Given this list of marker genes TERF2, PFDN5, KLHL6, UVSSA, ABRAXAS2, TLR6, IRS2, IRF2, HIVEP3, SPPL3, PGGT1B, EIF3H (eukaryotic translation initiation factor 3 subunit H), AKNA, LGALS1, MAP3K10, CCPG1, EIF3K, LIMK2, STK24, TMEM9B, KIAA0040, INPP5K, SHISA5, CLK3, C19orf12, ZSCAN25, VAMP8, ERP29, BRD4, MXD1 (NCBI Gene Id 4084), SSBP2, MAP1LC3B, STAT4, IFI27L2, VPREB3, DCAF5, PLGRKT, ZBTB24, IRAG2, ENPP1, FYCO1, ITGB2, ZC3HAV1, ACAP1, LINC01160, SYNE1, HPS6, CD38, GNPDA1, ZFYVE27, COX8A, FAM43A, MPPE1, SCAND1, SLC23A2, RAP1A, IL11RA, GKAP1, AKAP8L, BLOC1S1, NCKAP1L, NCOA7, PHKG2, SFI1, ABHD17B, NCF2, SMARCA2, TBC1D9B, GANC, TXNIP, EP300, ZNF597, GRK2, APOBEC3B, RAB4B, AKIRIN1, DCTN2, KCNN4, JUN, RAI1, NXPE2 (NCBI Gene Id 120406), TNFRSF18, NFKBIZ, POLG2, IFI44, ZNF292, TCP11L2, RNPEPL1, PPP3CA, RETREG3, FBXO3, RNASET2, ZMYND11, PSMB9, AAK1, CTSC, MICAL1, SLC35E3, TJP3, FERMT3, DGLUCY, DLG3, PECAM1 (platelet and endothelial cell adhesion molecule 1), TRIM59, TUG1, UAP1L1, BTG2, RPL18A, S100PBP, UBE2W, ABI1, QPCT, ITPR2, GPR34, TXLNG, CLU, LRSAM1, PLXNB2, TIGD2, KDM5A, MLLT3, EVI2B, PDE7A, FLOT2, NUDT14, PLD3, ARHGAP4, LIMD2, RRAGC (NCBI Gene Id 64121), TRPV2, CYB561A3, CNOT8, ASAH2, VPS37B, NEK9, GRINA, STX16, PDE1B, NEU1, AFF3, PXMP2, CAPNS1, HPSE, THBS1, GLG1, ATP8A1 (NCBI Gene Id 10396), TP53INP2, MTMR14, MEF2D, UTRN, PNISR, NIPAL3, CNPPD1, GNS (NCBI Gene Id 2799), NBR1, RAB19, MED12, GTPBP2, MCEE, ADGRL2, PNRC1, RERE, RENBP, PTPN6, SP110, IP6K2, UCP2, SLC28A2 (solute carrier family 28 member 2), FUCA1, WTIP, EMC3, CAPN1, CCS, CARD11, FAM76B, S100A11, C16orf54, TMEM71, CHST15 (NCBI Gene Id 9916), FAM76A, GSK3B, GLIPR2, FMO5, CSNK1D, BORCS6, RAB30, NAAA, DENND1C, ADAMTS6, S1PR4, HLA-DOA, P2RX4, DUSP3, CIB1, H2BC3, ADAMTS10, MTA3, ECI2, ENSA, WDFY2, here is a description of the gene set: Genes up-regulated in CD8 T cells, acute infection with LCMV-Armstrong: effectors at day 6 versus memory at day 30. Human Gene Set: GSE41867_DAY6_EFFECTOR_VS_DAY30_MEMORY_CD8_TCELL_LCMV_ARMSTRONG_UP species: Homo sapiens from publication Doering TA, Crawford A, Angelosanto JM, Paley MA, Ziegler CG, Wherry EJ (PMID 23159438) During acute viral infections, naïve CD8+ T cells differentiate into effector CD8+ T cells and, after viral control, into memory CD8+ T cells. Memory CD8+ T cells are highly functional, proliferate rapidly upon reinfection and persist long-term without antigen. In contrast, during chronic infections, CD8+ T cells become “exhausted” and have poor effector function, express multiple inhibitory receptors, possess low proliferative capacity, and cannot persist without antigen. To compare the development of functional memory T cells with poorly functional exhausted T cells, we generated longitudinal transcriptional profiles for each.